The following is a description of a gene set: species: Mus musculus Mouse Gene Set: GOBP_NEGATIVE_REGULATION_OF_DNA_RECOMBINATION Any process that stops, prevents, or reduces the frequency, rate or extent of DNA recombination., and this is the list of marker genes: Rtel1, Helb, Terf2, Msh3, Kat5, Mlh1, H1f5, Rad18, H1f6, H1f0, Recql5, Blm, H1f2, Lig3, Msh2, H1f10, Msh6, Terf2ip, Bcl6, Foxp3, Fbh1, Zscan4c, Klhl15, Trp53bp1, Mad2l2, Pot1b, H1f3, Senp3, BC037156, H1f1, Rmi2, H1f9, Ndfip1, Smchd1, Shld3, Plk1, Shld1, Csnk2a1, Kmt5a, Ankle1, Rif1, Parpbp, H1f8, Zranb3, Parp3, Polq, Radx, Abl1, C1qbp, Fancb (Fanconi anemia, complementation group B), Shld2, H1f4, Cgas, Ubqln4